Given this list of marker genes CKMT1A, MRPS2 (mitochondrial ribosomal protein S2), LEMD3, MRPL53, MRPS18C, TIMM23B (NCBI Gene Id 653252), MICU1, ATP1B4, NDUFA5, CPS1, NDUFAF1, ATAD3A, MRPS6, TIMM21, SDHB, MRPL21, TMEM186, NDUFB2 (NADH:ubiquinone oxidoreductase subunit B2), SLC25A10, HSPD1, PHB1, AIFM3, SMDT1, PRODH, PDE2A, COX4I1, PLA2G4B, FPGS, TMEM177, ENDOG, MRPS17, COX7A2, MRPL18, CIBAR1, PLPP6, MYOC, MRPL30, LMNB1, TIMM8B, COX6B2, NDUFA9, CLU, MRPL10, PGS1, NDUFAF4, PINK1, CYCS, MATR3, TMPO, SLC25A13, MRPS21, CLPX, UCP2, IMMP1L, DAP3, AMBP, TIMM29, NDUFB6, ATP11B, UQCRQ, TRMT10B, SLC25A41, NDUFA3, TMEM126A, MT-ND5, HCCS, MGARP (mitochondria localized glutamic acid rich protein), MRPL33, CPOX, DUSP18, CYP2U1, BDH1, LYN, COX7A2P2, ATP5ME, NEMP1, AIFM1, UQCRC1, ACAD11, FDXR, MRPL38, SLC25A24, TMEM242, BCL2L1, LDHD, TIMM22, MCU, TAFAZZIN, MRPL40, TRAP1, ATP5F1E, SLC25A38, MICU3 (mitochondrial calcium uptake family member 3), TRA2B, MRS2, ADCK1, CHCHD6, MRPL19, NDUFA2, FLVCR1, STMP1, NDUFB9, P2RX6, YME1L1, MT-CO3 (mitochondrially encoded cytochrome c oxidase III), ERAL1, SLC25A31, GADD45GIP1, ABCB10, TIMM9, MRPS15, LETM2, PLSCR3, MRPS26, CRAT, IFI6, MRPS12, MAIP1, LETMD1, UQCR11, MTX3, FECH, CDS2, MRPS27, OMA1, COX7B2, TMEM126B, MRPL50, COX8C, SLC25A51, MRPS24, UQCC1 (NCBI Gene Id 55245), COA8, TMEM160, SRC, SLC25A25, MRPL13, COX8A, AQP8, UNC50, NDUFV1, MRPS18B, CRLS1, DNAJC19, PAM16, NDUFB7, SLC25A29, MT-ATP8, CKMT2, COQ6, SLC25A39, NDUFA8, BCS1L, NDUFB5, NME4, EFHD1, SLC25A32, MRPS10, COQ10B, EXOG, APOOL, MTHFD2L, MT-ND3, MPC1L, GUF1, IMMT, SIRT5, NDUFC2-KCTD14, MRPL24, SLC25A23, COX4I2, LRPPRC, LEMD2, ATP5PO, TDH, ARL6IP6, UQCC5, NEU4, ALDH18A1, SHMT2, MRPL15, KCNK16, TAMM41, COQ7, MRPS5, HADHA, SLC22A14, NDUFA12, COX5A, MRPL2, ZMPSTE24 (zinc metallopeptidase STE24), DNAJC15, DUSP21, PRODH2, SLC25A14, MRPL42, ATP5MC2, SLC25A20, COX16, ATPAF1, PGAM5, SLC25A19, MRPL58, DPY19L2 (NCBI Gene Id 283417), ATP5MF, SDHC, ATP5MC3, SLC25A53, APP, ATP5MJ (NCBI Gene Id 9556), HSPA9, CYP27A1, SLC25A26, ABCB7, CABS1, KGD4, PSEN2, MTNAP1, UQCRFS1, CHCHD1, OTC, LRRK2, MRPS35, MRPL35, ATP5MC1, MRPL45, MRPS11, PDSS1, TOMM40, MICOS13, MRPL52, TMEM70, COX10, TERB2, PTCD3, MRPL11, SLC25A52, UQCRH, MRPL43, MRPS16, MT-ND1, OXA1L, MT-ATP6, NDUFC2, TMEM120B, CBX3, ATP5F1A, AGK, LGALS3, MTLN (NCBI Gene Id 205251), ACAD9, NDUFS8, MRPL12, PET100, COQ5, MRPL37, FAM169A, CYP11B2, SCO1, PLA2G4A, RDH13, COQ8A, FAM209B, UQCRC2, SNCA, TWNK, SLC25A48, SLC25A4, ATP5MGL, COX7C, NRM, CYP2E1, UQCC4, AURKAIP1, CHDH, SUN1, GHRHR, GATM, NEMP2, L2HGDH, COQ10A, CYP1A1 (NCBI Gene Id 1543), ERN1, SQOR, ATP5F1B (NCBI Gene Id 506), SLC30A2, MRPL39, NDUFA7, MRPL4, COX14, PISD, NDUFA11, RPS3, ITPR1, MRPL14, MRPL36, TYMS, STOML2, COX5B, MRPL51, MRPL32, NDUFAF2, UCP3, MAJIN, STAT3, NDUFA1, MRPS7, IMMP2L, ATP5MK, OPA1, MT-CO1 (NCBI Gene Id 4512), COX7A2L, MRPL22, KCNK9, MFSD10, TMEM14C, COX15, DNAJC30, EMD, NDUFB1, COQ2, MRPS23, RNF13, SMAD3, NDUFS1, MCUB (mitochondrial calcium uniporter dominant negative subunit beta), CYP11B1, NDUFB11, NDUFS4, MRPL41, TMX4, HSD3B2, TIMM8A, MT-ND6, DMAC1, NDUFB3, SMIM20, TIMM10, LBR, SLC25A30, NDUFV2, DPY19L2P2 (NCBI Gene Id 653912), CHCHD3, SLC25A27, MRPL46, SLC25A43, SLC25A47, PTPMT1, MRPL49, TIMM10B, TMEM223, RCC1L, ATP5PF, SFXN2, MRPL48, LDHB, NNT, SDHD, MTX2, NDUFA6, MRPL57, ATP5PD, TIMM23, SLC9B2, SPAG4, SLC25A34, NDUFAF6, KCNH1, COX7A1, ATPAF2, SIRT1, SPNS1, ALAS2, COQ3 (NCBI Gene Id 96592), ACOT9, MRPL17, TIMM13, COX6A2, MPV17L2, CKMT1B, DNAJC11, MRPL20, CYC1, SLC25A16, TMEM11, SLC8B1, GRPEL1, ECSIT (ECSIT signaling integrator), SUN2, NME6, NDUFA10, NDUFS7, SLC25A22, HIGD1A, TIMM50, TIMMDC1, MTG2, SFXN4, MRPL54, PMPCA, ENSG00000293600, ATP5F1D, TMEM201, TOR1AIP1, ETFDH, COA5, MT-CO2 (mitochondrially encoded cytochrome c oxidase II), PTGS2, ACADVL, DHFR2, MRPL28, SLC25A11, MICU2, BOK, AFG3L2, NDUFS6, MRPL47, NDUFS3, NDUFA4, THEM4, SLC25A33, UCP1, MRPS34, PPOX, NDUFB4, GHITM, NDUFV3, NUTF2, COA1, MPC1, MT-ND4L, MCUR1, MRPL44, SIGMAR1, SLC25A45, FAM209A, HIGD2A, MRPS25, SLC25A15, SFXN1, MRPS28, MRPL1, SFXN5, SLC25A40, COX11, SUN3, MRPS18A, UQCC3, PDSS2, COX6B1, UQCC2, SLC25A42, NDUFB8, SIRT4, COX7B, CYP11A1, SLC25A37, ATPSCKMT, SLC25A36, PSEN1, GCAT, COQ4, MPC2, NDUFAB1 (NCBI Gene Id 4706, NADH:ubiquinone oxidoreductase subunit AB1), NOA1, MRPS22, SDHA, MTG1, ATP5F1EP2, SLC25A21, IFI27, SLC41A3, CYP24A1, SCO2, ATP5MG, SLC25A35, MPV17, LETM1, SLC25A2, TMEM65, HADHB, RAB5IF, MRPL27, CPT2, TMEM120A, NDUFAF5, MT-CYB, UQCRHL, ROMO1, DMAC2L, COX18, FGR, SLC25A3, MRPL23, APOO, SAMM50, MTCO2P12, TMEM43, MRPL16 (NCBI Gene Id 64997), TIMM17A, NDUFS2, TM7SF2, RSAD2, PARL, UQCRB, SPHK2, ATP5PB, SLC25A1, MT-ND2, MTX1, ATP5F1C, SLC25A18, SLC25A28, FOXRED1, DHODH, MRPL3, MRPL34, MT-ND4, NDUFS5 (NCBI Gene Id 4725), PHB2, MRPS31 (mitochondrial ribosomal protein S31), CHCHD10, IFFO1, ATAD3B, DELE1, NDUFA13, SPG7, MRPS33, TTC19, MRPS30, TIMM44, HSD3B1, NDUFAF3, GPD2, COX6A1, HSP90B2P, PTPN1, SFXN3, COX6C, GRPEL2, COQ9, COX20, NDUFC1, CCDC51, NDUFB10, MRPL9, UQCR10, TIMM17B, SURF1, MRPL55, ABCB8, SLC25A5, ALAS1, SLC25A12, NPAP1, SUN5, SMAD1 (NCBI Gene Id 4086), SLC25A6, MTFP1, TERB1, MRPS9, UQCC6, COA3, MRPS14, MICOS10, here is a description of the gene set: Human Gene Set: GOCC_ORGANELLE_INNER_MEMBRANE The inner, i.e. lumen-facing, lipid bilayer of an organelle envelope; usually highly selective to most ions and metabolites. studied in species Homo sapiens